Given this list of marker genes ACIN1, WAPL, NOVA1, ZHX2, HMGB3, NR2C2AP (nuclear receptor 2C2 associated protein), RNGTT, CAV1 (caveolin 1), CRIM1, POMGNT1, ST7L, CAPZA2, FANCI, CTDNEP1, ALDH6A1, SF1, EPHB1, PRKAB1, CEBPB, CLIP3, GGT7, IP6K2, TRIP12, HLF, ZNF655, TCEANC2, FAM53C, HIC2, BAGE2, SERF2, RBM3, CAMK2G, PPP2R5E, SFRP2, ST8SIA2, PIGA (phosphatidylinositol glycan anchor biosynthesis class A), ZDHHC9, RORB, ZNF410, ING4, OAZ2, LRFN2, here is a description of the gene set: Human Gene Set: CCTGAGT_MIR510 studied in species Homo sapiens Genes having at least one occurence of the motif CCTGAGT in their 3' untranslated region. The motif represents putative target (that is, seed match) of human mature miRNA hsa-miR-510 (v7.1 miRBase).